The following is a description of a gene set: Any process that starts or increases the rate, frequency or extent of cardiac epithelial to mesenchymal transition, a transition where a cardiac epithelial cell loses apical/basolateral polarity, severs intercellular adhesive junctions, degrades basement membrane components and becomes a migratory mesenchymal cell. species: Mus musculus Mouse Gene Set: GOBP_POSITIVE_REGULATION_OF_CARDIAC_EPITHELIAL_TO_MESENCHYMAL_TRANSITION, and this is the list of marker genes: Twist1, Notch1, Tgfbr1, Acvr1, Eng, Jag1, Tgfb2, Tgfbr2, Emp2